Given this list of marker genes DUSP6, CD46, GDF15, EPHA2, LHX2, EFEMP1, FBN2, MAFF, FAM107A, TRIM22, SAT1, SLIT2, ZNF236, FZD5, TKTL1, NAV3, CAPN6, PLAGL1, ACKR3, CD9, IGFBP3, GATM, FUT9, COL9A3, SSX1, MTUS1, CD82, MPPED2, PLK2, BCL2, GAS6, FGF17, LGI1, PRR16, SMS, NPY2R, PDLIM5, TMEM255A, RIPPLY3, PMAIP1, COL4A5, HTR2C, ENPP4, PRSS23 (NCBI Gene Id 11098), SPRY1, NACA, SPON1, ELOC, HAUS6, FJX1 (NCBI Gene Id 24147), ZMYM2, CNTNAP2, DOCK3, ZBBX, LGR5, PROM1, LZTFL1, EMX2, COL4A6, NOTCH1, DMD, GALNT12, DGLUCY, AGPAT4, GRAMD1C, BEGAIN, WNT5B, FGF8, ARL4C, CHRDL1, SLC1A4, TP53TG1, PLEKHB1, F3, FOS, WIF1, SYNE2, PSTPIP2, DTNA, ZIC1, SOX3, NUAK2, SIX3, DDB2, HSPA1B, KLF3-AS1, QKI, CA2, GDF7, FEZF2, FOXG1, TNFRSF10B, NELL2, WASF1, CEP290, BTG3, BMP7, DLK1, HDC, CROT, CREB5, HSPA4L, SLITRK5, HTRA1, HLA-B, TTYH1, SPRY2, PALLD (NCBI Gene Id 51653), FUT8 (fucosyltransferase 8), ZMAT3, MFAP3L, NOS2 (NCBI Gene Id 4843), COCH, EFNA1 (ephrin A1), ETV5, TRIM24, FABP7, DSP, SPART (spartin), SORBS2, AMY1A, here is a description of the gene set: Genes down-regulated in the neural crest stem cells (NCS), defined as p75+/HNK1+. Vertebrate neural crest development depends on pluripotent, migratory precursor cells. Although avian and murine neural crest stem (NCS) cells have been identified, the isolation of human NCS cells has remained elusive. Here we report the derivation of NCS cells from human embryonic stem cells at the neural rosette stage. We show that NCS cells plated at clonal density give rise to multiple neural crest lineages. The human NCS cells can be propagated in vitro and directed toward peripheral nervous system lineages (peripheral neurons, Schwann cells) and mesenchymal lineages (smooth muscle, adipogenic, osteogenic and chondrogenic cells). Transplantation of human NCS cells into the developing chick embryo and adult mouse hosts demonstrates survival, migration and differentiation compatible with neural crest identity. The availability of unlimited numbers of human NCS cells offers new opportunities for studies of neural crest development and for efforts to model and treat neural crest-related disorders. Human Gene Set: LEE_NEURAL_CREST_STEM_CELL_DN species: Homo sapiens from publication Lee G, Kim H, Elkabetz Y, Al Shamy G, Panagiotakos G, Barberi T, Tabar V, Studer L (PMID 18037878)